Given this list of marker genes NPNT, LCN2, DSG2, CHEK1, FRRS1, HOMER2, PLET1, ETV1, SKP1, CD82, KCNN4, TPD52, RRM2, ACSL4, SLC66A2, ABRACL, TCEAL9, ID2, DOK1, here is a description of the gene set: from publication Landis MD, Seachrist DD, Montañez-Wiscovich ME, Danielpour D, Keri RA (PMID 15897883) Up-regulated genes from top genes out of the 324-gene signature identified in the pre-neoplastic tissue adjacent to the mammary tumors induced by transgenic expression of ERBB2. Human Gene Set: LANDIS_ERBB2_BREAST_PRENEOPLASTIC_UP species: Mus musculus Upregulation of HER2/ErbB2/Neu occurs in 15-30% of human breast cancers and correlates with poor prognosis. Identification of ErbB2/Neu transcriptional targets should facilitate development of novel therapeutic approaches. Development of breast cancer is a multistep process; thus, to identify the transcriptomes associated with different stages of progression of tumorigenesis, we compared expression profiles of mammary tumors and preneoplastic mammary tissue from MMTV-Neu transgenic mice to expression profiles of wild-type mammary glands using Affymetrix microarrays. We identified 324 candidate genes that were unique to ErbB2/Neu-induced tumors relative to normal mammary gland tissue from wild-type controls. Expression of a subset of these genes (82) was also changed in the preneoplastic mammary glands compared to wild-type controls, indicating that they may play a pivotal role during early events of ErbB2/Neu-initiated mammary tumorigenesis. Further analysis of the microarray data revealed that expression of several known transforming growth factor (TGF)-beta target genes was altered, suggesting that the TGF-beta signaling cascade is downregulated in ErbB2/Neu-induced tumors. Western blot analysis for TGF-beta-Receptor-I/ALK5 and immunohistochemistry for TGF-beta-Receptor-I/ALK5 and phosphorylated/activated Smad2 confirmed that the Smad-dependent TGF-beta signaling cascade was inactive in these tumors. Although absent in most of the tumor, phosphorylated Smad2 was present in the periphery of tumors. Interestingly, presence of phosphorylated/activated Smad2 correlated with expression of Activin-Receptor-IB/ALK4, suggesting that although Smad-dependent TGF-beta signaling is absent in ErbB2/Neu-induced tumors, Activin signaling may be active at the leading edge of these tumors. Cumulatively, these data indicate that the TGF-beta pathway is intrinsically suppressed in ErbB2/Neu tumors via a mechanism involving loss of TGF-beta-Receptor-I/ALK5.